Given this list of marker genes Ptprz1, Atp8b2, Hcar1, Gsc, Kif13a, Zfp704, Gpc4, Trps1, Grip2, Eif4enif1, Clcn3, Abi3bp, Rdx, Sertad2, Arl6ip1, Cxxc4, 1500009L16Rik, Pou3f4, Spast, Zfp46, Cfap90, Pcdha9, Tmeff2, Rasef, Kat6b, Fhl1, Pcdhac2, Cdk5r1, Klhl34, Onecut2, Hoxa9, Pnisr, Hbp1, Zc3h12d, Cdkn2aip, Usp27x, Rasgef1a, Bzw2, Mdh1, Nsun4, Kras, Zfp608, Kmt2c, Ccdc121rt3, Pcdha6, Pcdha11, Nfyb, Rsf1, Shisa4, Mef2a, Rpgrip1l, Sppl2a, Elmod1, Pcdhac1, Pde12, Enah, Ttbk2, Nr3c1, Abtb2, Cubn, Tbpl1, Pdpk1, Cd84, Pcdha10, Pappa, Dagla, Ythdf1, Sash1, Rnf207, Yy1, Lpar4, Parp4, Mbtps2, Pcdha4, Cdh11, Rufy3, Rab39b, Nkx2-1, Zfp711, Cd2ap, Vps37a, Pcdha2, Ube2e3, Dda1, Ccr7, Pcdha3, Cers4, Vamp4, Gpx8, 6430571L13Rik, Erlin2, Hoxc6, Slitrk4, Oga, Lpl, Jam2, Pcdha5, Tbr1, Gypc, Larp4b, Lsm14a, Pck1, Rnf128, App, Spef2, Khdrbs1, Mycbp2, Chmp4b, Aldh1a1, Nr4a2, Vps54, Ccdc92, Mtap, Htr7, Pcdha1, Med13, Rnf152 (NCBI Gene Id 320311), Cacnb4, Vdac1, Ccdc88a, Ireb2, Ints7, Nxf3, Pcdha7, Nfix, Pcdha12, Tpp2, Rnf115, Anp32e, Tut4, Nwd1, Aldh1a3, Nckap5, here is a description of the gene set: studied in species Mus musculus from publication Chen Y, Wang X (PMID 31504780) Mouse Gene Set: MIR_9B_3P Genes predicted to be targets of miRBase v22 microRNA mmu_miR_9b_3p in miRDB v6.0 with MirTarget v4 prediction scores > 80 (high confidence targets).